Given this list of marker genes Neu2, St3gal3, Hexa, St6galnac5, St8sia4, Glb1, Itgb8 (NCBI Gene Id 320910), Cln6, St6galnac6, St3gal1, St6galnac4, Neu4, B4galt5, St6galnac3, Neu1, Naglu, 6430550D23Rik, St8sia2, Gm2a, Neu3, St6galnac1, B3galt4, Abca2, St8sia6, B4galnt1, Hexb, B4galt6, St8sia3, St3gal2, here is a description of the gene set: The chemical reactions and pathways involving ceramide oligosaccharides carrying in addition to other sugar residues, one or more sialic acid residues. Mouse Gene Set: GOBP_GANGLIOSIDE_METABOLIC_PROCESS species: Mus musculus